Given this list of marker genes SLC37A4, F5, LMAN1, MCFD2, AHCY, here is a description of the gene set: Any deviation from the activity of coagulation factor V. Human Gene Set: HP_ABNORMAL_COAGULATION_FACTOR_V_ACTIVITY Abnormal coagulation factor V activity species: Homo sapiens